Given this list of marker genes Eno1b, Eno2, Eno3, Eno4, Eno1, here is a description of the gene set: Catalysis of the reaction: 2-phospho-D-glycerate = phosphoenolpyruvate + H2O. Mouse Gene Set: GOMF_PHOSPHOPYRUVATE_HYDRATASE_ACTIVITY studied in species Mus musculus